The following is a description of a gene set: species: Homo sapiens Catalysis of the hydrolysis of a single C-terminal amino acid residue from the C-terminus of a polypeptide chain by a catalytic mechanism that involves a catalytic triad consisting of a serine nucleophile that is activated by a proton relay involving an acidic residue (e.g. aspartate or glutamate) and a basic residue (usually histidine). Human Gene Set: GOMF_SERINE_TYPE_CARBOXYPEPTIDASE_ACTIVITY, and this is the list of marker genes: CPVL, SCPEP1, PRCP, CTSA, CPD